Given this list of marker genes LIG1, HADHA, STAT5B, LCAT, GTF2E1, CAMK2G, GNS, TLE1 (TLE family member 1, transcriptional corepressor), TGIF1, ME2, RPL14, ABCD1, TBL3, VEGFA, ZNF274, CDKN2A, SNRPD1, SLC2A5, CITED2, MATN1, IFRD2, GAPDH, ZNF212, BMAL1, GET3, IK, LRPPRC, SLK, PRKCB, SLC8A3, FRMPD4, BTN3A2, POLR2C, STAT1, GSPT1, PDCD4, GUCY2C, SLA, ABCG1, OVGP1, PDE4B, SLC25A13, IGHV5-78, JADE3, here is a description of the gene set: studied in species Homo sapiens Human Gene Set: SHIPP_DLBCL_CURED_VS_FATAL_DN Diffuse large B-cell lymphoma (DLBCL), the most common lymphoid malignancy in adults, is curable in less than 50% of patients. Prognostic models based on pre-treatment characteristics, such as the International Prognostic Index (IPI), are currently used to predict outcome in DLBCL. However, clinical outcome models identify neither the molecular basis of clinical heterogeneity, nor specific therapeutic targets. We analyzed the expression of genes in diagnostic tumor specimens from DLBCL patients who received cyclophosphamide, adriamycin, vincristine and prednisone (CHOP)-based chemotherapy, and applied a supervised learning prediction method to identify cured versus fatal or refractory disease. The algorithm classified two categories of patients with very different five-year overall survival rates (70% versus 12%). The model also effectively delineated patients within specific IPI risk categories who were likely to be cured or to die of their disease. Genes implicated in DLBCL outcome included some that regulate responses to B-cell-receptor signaling, critical serine/threonine phosphorylation pathways and apoptosis. Our data indicate that supervised learning classification techniques can predict outcome in DLBCL and identify rational targets for intervention. Top 50 down-regulated markers for the diffused large B-cell lymphoma (DLBCL) that distinguished between cured and fatal/refractory clinical outcomes. from publication Shipp MA, Ross KN, Tamayo P, Weng AP, Kutok JL, Aguiar RC, Gaasenbeek M, Angelo M, Reich M, Pinkus GS, Ray TS, Koval MA, Last KW, Norton A, Lister TA, Mesirov J, Neuberg DS, Lander ES, Aster JC, Golub TR (PMID 11786909)